Given this list of marker genes AP2M1, SH3BP4, NFYB, CUTA, ATP5F1A, DGAT2, LIN7C, E2F3, THOC7, UBE2Q2, GALNT9, ST18, DUSP19, ADPGK, POLD4, ATF6B, CTU2, GPR155, DESI1, FBXO30, LDHB, ETS1, ENPP1, ALDH1A2, EHHADH, HTATSF1, PCDH7, TPBG (NCBI Gene Id 7162), GOLGA2, SPATA13, AK3 (NCBI Gene Id 50808), SLC16A1 (solute carrier family 16 member 1), ZYG11B, METTL2B (NCBI Gene Id 96672), UCHL3, PLP1, ZNF484, MGAT4A, SNORD58B, PEX19, ATF2, USP5, MAST2, CUL1, NAT10, ASAH1 (NCBI Gene Id 79795), ANXA6, UBL4B, GPR18, RYK, CFH, RASAL2, TMEM184C (transmembrane protein 184C), CAVIN4, UBE2V2, SLC4A2, GIMAP4, PLK1 (NCBI Gene Id 5347), HSD17B10, CYTH2, SLC38A6, KCNK7, PRRC1, EIF3J, CUL7, WDR13, VAPA, NCDN, RNF170, SMYD3, EVI5L, SYNCRIP, GLS, IGF1, UBE3A, CDKN2B, RAD17, ZNHIT6, PPEF2, DFFA, TJP2, C1QBP, P2RY2, GSAP, E2F6, TLCD3A, NDUFA3, ACAD9, TNFRSF18, SNX13, TMEM150A (NCBI Gene Id 200551), CEBPD, RNMT, ATP8B2, SLC39A11, C1QTNF12, UNC5C, LZTFL1, ITGA9, FBXO9, PTTG1IP, ELOVL1, TOMM6, ATXN3, RSPRY1, DDX17, UFD1, PDP2, NANS, TLN2, SMC3, COX6B1, HACL1, MIA3, SLC25A37, MARCKS (myristoylated alanine rich protein kinase C substrate), KLHL2, RAB10, NRIP1, ACVR2A, DEPDC5, NADK, GNG12, KTN1, ERRFI1, PPP1R21, ATP2A3, CDC16, MCFD2, MECOM, C18orf32, IQCB1, RASGRP1, CEP57, SMARCA5, AIFM1, MIB1, RPL32, PDCL3, CTPS1, TUBA4A, GUSB, SH3TC1, UBE2E2, EXOC6B, TMBIM1, NTAQ1, CSNK1G3, RALGAPA1, PTPN4, AGO3, ARSA, TMTC3, MAPKAPK2, ALKBH7, GDI1, PLD2, TMED3, MOB3B, PANX2, GSTA3, SLC12A2, H6PD, ALG12, PHLDB1, CEACAM19 (NCBI Gene Id 56971), SERTAD2, PIK3CA (NCBI Gene Id 5290), WDR36, BSCL2, FOXP4, GRAMD1A, THUMPD3, PTP4A3, ARL6, GTF2E2, SEC22A, RAB11A (NCBI Gene Id 8766), XPO5, RAB32, H3-3A, CDK7, SHROOM4, CDC27, here is a description of the gene set: from publication Ramirez K, Chandler KJ, Spaulding C, Zandi S, Sigvardsson M, Graves BJ, Kee BL (PMID 22608498) Human Gene Set: GSE37301_GRANULOCYTE_MONOCYTE_PROGENITOR_VS_RAG2_KO_NK_CELL_UP species: Homo sapiens Genes up-regulated in granulocyte-monocyte progenitor versus RAG2 knockout NK cells. Expression profiling of Rag2-deficient Ets1++ and Rag2-deficient Ets1-- mature NK cells and WT bone marrow progenitors, WT T cells, and WT Pro B cells